Given this list of marker genes Lgals9, Gpr183, Abcc1, F11r, Dock8, Ccl26, Ch25h, Wnt5a, Madcam1, Adtrp, Myo1g, S1pr1, Fut4, Il27ra, Gas6, Slc12a2, Crk, Cxcl12, BC037156, Coro1a, Tnfsf4, Tnfsf14, Apod, Hsd3b7, Rhoa, Crtam, Cd200r1, Padi2, Il4, Ascl2, Nedd9, App, Ggt5, Gba1, Ripor2, Cx3cl1, Akt1 (NCBI Gene Id 268604), Pycard, Cd69, Ccl12, Spn, Oxsr1, Cxcr3, Icam1, Jam2 (NCBI Gene Id 76825), Itga4, Gcsam, Stk10, Artn, Med23, Cxcl13, Mia3, Cd99l2, Abl2, Ccr7, Ccr2, Aire (autoimmune regulator), Lrch1, Ccl20, Wasl, Ccl5, Gpr15, Msn, Slc8b1, Adam8, Ccl2, Itgb7 (integrin beta 7), Spns2, Cxcl16, Abl1, Ccl3, Cd200, Itgb3, Adam10, Wnk1, Lrp12, Aif1, Ptk2b, Cxcl11, Tbx21, Crkl, Gnai1, Tnfrsf14, Xcl1, Ext1, Ripk3, Selenok, P4hb, Gpr15lg, Klrk1, Cxcl10, Cyp7b1, Stk39, Ecm1, Tmem102, Fut7, Ccr6, Msmp, Cxcl14, Fadd, Gata3, Cklf, Itgal, Ccl21a, Plec, Adam17, Cadm1, Ccl7, here is a description of the gene set: studied in species Mus musculus The movement of a lymphocyte within or between different tissues and organs of the body. Mouse Gene Set: GOBP_LYMPHOCYTE_MIGRATION